Given this list of marker genes Bicd2, Arfrp1, Vps13a, Gcc2, Arl5b, Gak, Tmed10-ps, Rab33b, Optn, Golph3l, Golph3, Arl5a, Sys1, Pacs1, Cog7, Vps13c, Obsl1, Zdhhc15, Arl5c (ADP-ribosylation factor-like 5C), Sorl1, Csnk1d, Ripor1, Gbp5, Vps13d, Tmed10, Rab6b (NCBI Gene Id 77488), Rab6a, Atg9a, Gbf1, Arl1, Paqr3, Ift20, here is a description of the gene set: Mouse Gene Set: GOBP_PROTEIN_LOCALIZATION_TO_GOLGI_APPARATUS A process in which a protein is transported to, or maintained in, a location within the Golgi apparatus. species: Mus musculus